Given this list of marker genes Lsm3, Edc3, Cnot6l, Patl2, Lsm14a, Rc3h1, Cnot7, Dync1h1, Pan3, Cnot1, Ago2, Lsm4, Cnot2, Cnot6, Noct, Patl1, Limd1, Eif4enif1, Atxn2, Tnrc6a, Pan2, Ddx6, Nbdy, here is a description of the gene set: species: Mus musculus Mouse Gene Set: GOBP_P_BODY_ASSEMBLY The aggregation, arrangement and bonding together of proteins and RNA molecules to form a cytoplasmic mRNA processing body.